Given this list of marker genes CDKN2C, TMEM158, TPT1, RBM6, ETFA, KARS1, SV2A, PTPN7, STAT3, RPH3A, CACNA1D, WSB2, PSMB6, FAM168B, KIF14, STAT6, PFKFB1, ALDH9A1, PPBPP2, HTRA2, MAGEB2, PEX6, MOB1A, PIKFYVE, ARHGEF6, TUBB, MAP2K6, CDC42, CRKL, CLC, THOC2, CNPPD1, SRSF3, PSMD6, FIG4, CLIP2, NDUFA7, PKMYT1, SAMM50, CHUK, DEGS1, ADGRL2, GPR20, GART, RNF4, RBBP8, RPS6, KIF21B (kinesin family member 21B), ATP6V1D, CHP1, ATXN10, HOXD8, WDR7, FARP1, DOLK, TCERG1, INPP5D, GTF3C2, BTRC, PDLIM7, POLR2D, ZNF410, HMGN2, GYS1, AMELX, RHEB, CAPN15, PCM1, FABP5, PSG3, LASP1, CRIPTO, COPS6, GANAB, PFKM, MFNG, RPS29 (ribosomal protein S29), TAF11, MPDU1, COIL, RNASE1, ARPC4, NBR1, CREB3, ACOT8, SASH3, TRIM38, HSBP1, IL4 (NCBI Gene Id 3565), RDH11, TAGLN, LYZL6, CD1A, SRRD, LAPTM4B, MISP, EXTL3, UBE2N, TMEM109, KDM5D (NCBI Gene Id 9773), ANXA1, MSMB, YARS1, DIAPH1, CHN2, MBD1, PPP1R10, PARM1, SUMO4, PDHA2, APOBEC3C, LTBP2, HUS1, KIDINS220, SLC35A3, CAP1, DECR1 (2,4-dienoyl-CoA reductase 1), LIAS, TMBIM6, PPID, METTL3, KCNA3, PANK3, GOSR1, CARS1, HUWE1, ETV6, EFNB3, ST3GAL4, ACVRL1, EIF6, RPE, RAD23B, NPEPPS, NDUFS4, MSH3, TM7SF2, LDHB, DMAC2L, POLE3, STK38, H2AZ1, ACTR2 (NCBI Gene Id 10097), CPSF1, ZG16, ESYT1, PLCB2, EIF3I, IDH3A, BNIP1, STXBP2, ARPC3, CARD8, ATAD2B, SPTSSA (NCBI Gene Id 171546), ERCC2, CX3CL1, PRODH, VAMP3, MORF4L2, MRC2, PLOD3, TPM1, EIF4G2, CERS6, ANXA6, IKBKG, BAAT (bile acid-CoA:amino acid N-acyltransferase), PI3, MLEC, CKAP5, CIB1, SLC33A1, MYH6, PLAAT3, IKBKB, HMGCS2, ATRN, MCF2, P2RY11, NPRL2, PTAFR, IK, BRMS1, ALDH1B1, OGFR, KCNJ4, FSHR, CAMK1, RPS4X, PPP1CB, RER1, ANP32A, TECR, ITGAM, GPR35, ORC4, CCNE1, UQCRC1, here is a description of the gene set: studied in species Homo sapiens Genes up-regulated in comparison of dendritic cells (DC) exposed to 5 worm/well B. malayi versus macrophages exposed to 5 worms/well B. malayi. Monocyte-derived dendritic cells (DC) and macrophages (MΦ) generated in vitro from the same individual blood donors were exposed to five different pathogens, and gene expression profiles were assessed by microarray analysis. Responses to Mycobacterium tuberculosis and to phylogenetically distinct protozoan (Leishmania major, L. donovani, Toxoplasma gondii) and helminth (Brugia malayi) parasites were examined, each of which produces chronic infections in humans yet vary considerably in the nature of the immune responses they trigger. from publication Chaussabel D, Semnani RT, McDowell MA, Sacks D, Sher A, Nutman TB (PMID 12663451) Human Gene Set: GSE360_DC_VS_MAC_B_MALAYI_LOW_DOSE_UP